Given this list of marker genes Tifab, Ptgs2, Bdkrb2, Bad, Usp15, Ybx3, Epo, here is a description of the gene set: Any process that modulates the frequency, rate or extent of intrinsic apoptotic signaling pathway in response to osmotic stress. Mouse Gene Set: GOBP_REGULATION_OF_INTRINSIC_APOPTOTIC_SIGNALING_PATHWAY_IN_RESPONSE_TO_OSMOTIC_STRESS studied in species Mus musculus